Given this list of marker genes FXR1, CSF2, CHRNB2, PARP1, ADRB1, GHRHR, NPS, PER3, HCRTR2, KCNA2, ADORA1, ADORA2A, NPY2R, NLGN1, NR1D1, DRD2, GHRH, MTNR1B (melatonin receptor 1B), PTGDS, CRH, GHRL, NMU, here is a description of the gene set: studied in species Homo sapiens Human Gene Set: GOBP_REGULATION_OF_CIRCADIAN_SLEEP_WAKE_CYCLE Any process that modulates the frequency, rate or extent of the circadian sleep/wake cycle.